The following is a description of a gene set: studied in species Mus musculus Mouse Gene Set: GOMF_DIHYDROPYRIMIDINASE_ACTIVITY Catalysis of the reaction: 5,6-dihydrouracil + H2O = 3-ureidopropionate., and this is the list of marker genes: Dpysl5 (dihydropyrimidinase-like 5), Dpysl2, Dpys, Dpysl4, Crmp1, Dpysl3